Given this list of marker genes Oaf, Adgrg1, Nrip1, Tsc22d1, Ptprcap, Tmsb10, Cd27, Tspan2, Ednra, Nrgn, Flt3, Erg, Ly86, Gem, Cd34, Cxxc5, Satb1 (NCBI Gene Id 70334), Il7r, Cd93, Itgb7, Calcrl, Meis1, Cd244a (CD244 molecule A), Ebf1, here is a description of the gene set: Down-regulated genes in myeloid progenitors immortalized by HOXA9 vs those immortalized by HOXA9 and MEIS1. Meis1 is a homeodomain transcription factor coexpressed with Hoxa9 in most human acute myeloid leukemias (AMLs). In mouse models of leukemia produced by Hoxa9, Meis1 accelerates leukemogenesis. Because Hoxa9 immortalizes myeloid progenitors in the absence of Meis1 expression, the contribution of Meis1 toward leukemia remains unclear. Here, we describe a cultured progenitor model in which Meis1 programs leukemogenicity. Progenitors immortalized by Hoxa9 in culture are myeloid-lineage restricted and only infrequently caused leukemia after more than 250 days. Coexpressed Meis1 programmed rapid AML-initiating character, maintained multipotent progenitor potential, and induced expression of genes associated with short-term hematopoietic stem cells (HSCs), such as FLT3 and CD34, whose expression also characterizes the leukemia-initiating stem cells of human AML. Meis1 leukemogenesis functions required binding to Pbx, binding to DNA, and a conserved function of its C-terminal tail. We hypothesize that Meis1 is required for the homing and survival of leukemic progenitors within their hematopoietic niches, functions mediated by HSC-specific genes such as CD34 and Fms-like tyrosine kinase 3 (FLT3), respectively. This is the first example of a transcription factor oncoprotein (Meis1) that establishes expression of a tyrosine kinase oncoprotein (FLT3), and explains their coexpression in human leukemia. This cultured progenitor model will be useful to define the genetic basis of leukemogenesis involving Hoxa9 and Meis1. from publication Wang GG, Pasillas MP, Kamps MP (PMID 15755900) studied in species Mus musculus Mouse Gene Set: WANG_IMMORTALIZED_BY_HOXA9_AND_MEIS1_DN